Given this list of marker genes Tppp, Ubxn2b, Ino80, Chmp1b, Kpna7, Kif11, Cspp1, Poc1a, Sncg, Mad2l1, Afg2a, Cep250, Plk2, Ccdc117, Aspm, Cetn1, Ccdc69, Haspin, Eml2, Efhc1, Kif3a, Nme7, Tubb4b, Aunip, Dync1i1, Nek2, Mapkbp1, Terf1, Afg2b, Umod, Mzt2, Dsn1, Chmp4b, Tmem9, Cdc16, Plk1 (polo like kinase 1), Arhgef2, Ralbp1, Ctnnb1, Myh10, Trat1, Septin12 (septin 12), Hspb1, Cdc14b, Tubb2b, Cep170, Bmyc, Luzp1, Anxa11, Git1, Chmp2b, Haus4, Cep85, Birc5, Ckap2l, Chmp2a, Tubgcp6 (NCBI Gene Id 328580), Nin, Arl8a, Cdc27, Nudcd2, Evi5, Cxcr2, Gpsm2, Haus5, Map10, Alpk1, Katnb1, Klhl21, Cdc42, Aaas, Fbf1, Calm3, Alms1, Unc119, Hdac3, Rgs14, Kif14, Pmf1, Cep63, Dynlt2b, Dr1, Cenpv, Chmp7, Bod1, Kif2c, Tbck, Numa1 (NCBI Gene Id 94347), Kifc5b, Taf1d, Npm1, Kif20b, Kat2b, Tubgcp4, Lzts2, Ska1, Limk2, Diaph3, Ccdc57, Cul3, Topbp1, Fmn2, Chmp5, Cep19, Pafah1b1, Hecw2, Ik, Smc6, Ypel5, Smc3, Ptpn7, Lats1, Ciao1, Ccar2, Plk5, Ercc2, Atm, Cdc6, Pnma5, Kntc1, Mapre1, Tpt1, Mad2l1bp, Dync1li1 (dynein cytoplasmic 1 light intermediate chain 1), Phlpp2, Arl8b, Ciao2b, Klhl42, Parp4 (poly (ADP-ribose) polymerase family, member 4), Map4, Capn6, Nup85, Ptp4a1, Kash5, Vps4a, Tubgcp3, Kif23, Cep104, Spice1, E4f1, Fry, Mapk14, Csnk1d, Zfp207, Katnbl1, Bub1b, Zw10, Tada2a, Mad2l2, Akt1, Wdr5, Mapk15, Poc1b, Eml4, Anapc5, Brcc3, Cd180, Slc25a5, Fam110a, Dnali1, Ift43, Cenpe, Nde1, Cep89, Espl1, Mapk1ip1, Dzip1l, Pinx1, Ctdp1, Nudc, Sgo1, Iqcb1, Kif18b (NCBI Gene Id 70218), Rassf10, Trim75, Dynlt1b, Pkp4, Rcc2, Inppl1, Tpx2, Hsf1, Eml1, Cep95, Lsm14a, Aurka, Nup62, Spin1, Ankrd53, Clta, Cdk5rap2, Myf6, Eml3, Or2a7, Kmt5b, Plk3, Cep350, Tubgcp5 (NCBI Gene Id 259278), Cdc20, Champ1, Map1s, Shcbp1l, Polb, Kbtbd8, Pla2g4c, Nedd1, Hnrnpu (NCBI Gene Id 98724), Bcl2l10, Ikbkg, Agbl5, Ska2, Odf2, Rb1, Mtcl1 (NCBI Gene Id 68617), Aurkb, Cfap53, Mis12, Septin6, Zzz3, Cep295, Lats2, Chmp1a, Acot13, Tada3 (NCBI Gene Id 68474), Haus8, Cenpf, Tpr, Dido1, Ect2, Cdc7 (NCBI Gene Id 12545, cell division cycle 7), Tmem201, Ppp2ca (protein phosphatase 2 (formerly 2A), catalytic subunit, alpha isoform), Katnal1 (NCBI Gene Id 231912), Cntrl, Birc6, Haus2, Cdc14a, Rif1, Tbccd1 (NCBI Gene Id 70573), Ndel1, Chmp1b2, Clasp2, Ckap5, Ngrn, Misp, Spout1, Smc1a, Emd, Pard3, Maea, Kat2a, Kif18a, Dctn3, Slc34a1, Crmp1, Kif2a, Vps4b, Tubb2a, Bbln, Tubb5, Spag5, Ccsap, Bex4, Stag1, Rps6ka2, Mak, Nsfl1c, Rps6ka1, Dynll1, Tubb1, Shcbp1, Wdr62, Arhgap6, Lemd2, Adrb2, Specc1l, Prpf19, Rmdn1, Rps3, Nr3c1, Map7d1, Wapl, Rab11a, Septin1, Dcun1d5, Stag2, Rae1, Tnks, Chmp3, Ttl, Sbds, Ttc28, Ccnb1-ps, Dnaaf5, Katnal2, Mapk1, Ankfn1, Ppp2cb, Golga2 (NCBI Gene Id 99412), Arl3, Poldip2, Ttll12, Sgf29, Nek6, Nsmce1, Map2k5, Mad1l1, Cltc, Pin4, Cdca8, Plekhg6, Tbl1x, Mapre2, Epb41, Prc1, Pkhd1, Nsun2, Yeats2, Atat1, Nsl1, Ccdc66, Cdc25b, Tubg1, Enkd1, Haus1, Odam, Hspa2, Mbip, Ckap2, Chmp6, Ska3, Kif16b, Calm2, Bnip2, Uxt, Bex6 (brain expressed family member 6), Cep128, Rassf1, Cpeb1, Gem, Kifc1 (kinesin family member C1), Tubg2, Wdr73, Gpx2, Cttn, Tubb6, Gsk3b, Neil2, Dctn1, Spdl1, Cdk1, Rock2 (Rho-associated coiled-coil containing protein kinase 2), Fam110c, Myc, Rtraf, Rsph1, Cep44 (NCBI Gene Id 71256), Haus7, App, Csnk1a1, Cbx3, Kif20a, Mapre3, Kif2b, Tubgcp2, Kif22, Rangap1, Nedd9, Map7d3, Dctn4, Haus6, Racgap1, Flcn, Irag2, Katna1, Septin2, Pycr3, Hepacam2, Clasp1, Ddx11, Tubb4a, Rmdn2, Kat5, Kif15, Mzt1, Klhl22 (NCBI Gene Id 72509), Sac3d1, Jtb, Capg, Aurkc, Ncor1, Nek7, Hnf4g, Firrm, Psrc1, Cbx1, Spag8, Chmp4c, Dlgap5, Dapk3, Wnk1, Trappc14, Invs, Diaph1, Kat14, Cyld, Tfdp2, Mical3, Haus3, Anapc7, Ccna1, Mms19, Camk2b, Calm1, Ttc23l, Tacc3, Cep162, Myh9, Spast, Nubp2, Bccip, Septin7, Map9, Dync2i1, Ccnb1, Pkd2, Abraxas2, Arhgef7, Hmmr, Fam161a, Topors, Sirt2, Incenp, Fam83d, Dynlt3, Dcdc2a, Bora (bora, aurora kinase A activator), Tbl1xr1, Rmdn3, Kifap3, Knstrn, Tubb3, Fbxo5, Nusap1, here is a description of the gene set: species: Mus musculus The array of microtubules and associated molecules that forms between opposite poles of a eukaryotic cell during mitosis or meiosis and serves to move the duplicated chromosomes apart. Mouse Gene Set: GOCC_SPINDLE